The following is a description of a gene set: Human Gene Set: GATA1_04 Genes having at least one occurrence of the motif NNCWGATARNNNN in the regions spanning 4 kb centered on their transcription starting sites. This matches the GATA1 transcription factor binding site V$GATA1_04 (v7.4 TRANSFAC). studied in species Homo sapiens, and this is the list of marker genes: CLCN5, PRDX2, CHCHD7, ROS1, MAP4K5, MYOT, PCDH7, MSR1, HES1 (hes family bHLH transcription factor 1), TFR2, PDZD2, SLC26A7, IL34 (interleukin 34), RBPMS, APOBEC2, TFAP2D, NR5A2, CTCF, CEBPB (CCAAT enhancer binding protein beta), HBZ, TSPEAR, RHOBTB2, CALM2, TNXB, TACC1, NFE2, IGF1, TFEC, HOXB9, SLC8A3, MYO1C, ISL1, LRR1, SLC35A2, SYNPO, ARHGEF37, BIRC8, PRSS1, HIC1, DRD3, CPLX2, TMEM196, PPP2R3A, ARPC2, IP6K2, GUCA2A, SLITRK2, KIF3C, JUN, NEUROG3, MMP23B, CNN1, LINC01341, HS3ST4 (NCBI Gene Id 9951), ADM, SYN1, PRR18, CACNB3, PAN2, HOXC12, TCF21, UBE3A, WFIKKN2, LIN28A, HIPK1, KIRREL2, EFHC2, SAMD11, ALDH1A1, MBNL2, CCSER2, MAP4K3, KLF1, CELA3A, SCUBE3 (NCBI Gene Id 222663), MOGAT2, GBX2, ICAM4, GPX5, BNC2, TSC22D3, AMHR2, TBX5, ZBTB20, FBXL18, FAM76A, ALDH18A1 (aldehyde dehydrogenase 18 family member A1), CD34, C3AR1, HOXA10, HAMP, PON3, BMP6, IL5, HOXA13, TAFA1, PLAG1, MMP23A, PLCXD2, SPATS1, MAMDC4, ESRRB (estrogen related receptor beta), GATA1, TSHB, MSI2, MST1, PRKAA1, PDGFRA, FZD4, EDA, ECHDC2, UBE2H, SLC41A1, CAPN1, PAPPA, PHF21A, INTS5, EPO, PRELID1, P3H2, LMO2, PITX2, RNF185, EPB42, SEMA4D, C22orf31, PTGDR2, CLDN14, SLC14A1 (NCBI Gene Id 6563), CELA3B, RORA, HOXB7, BSN, RUNX1T1 (NCBI Gene Id 862), NDUFA4L2, AIF1L, DSPP, EYA4, CCL27, CYP11A1, CALHM5, GADD45G, TNFRSF19, ABCA12, SRSF1, SYNE1, ZIC1, ZNF385B, MECOM, PKIA, LUC7L3, ABCG8, CCDC80, COL17A1, AQP2 (NCBI Gene Id 359), ID3, HOXD1, CASZ1, CALD1, TWIST1, DNAJB4, PNLIPRP2, XIRP1, S1PR2, PRSS3, PNLIPRP1, FLI1, FAM117A, RAB3C (NCBI Gene Id 115827), RALGPS2, FBXO11, PTPRR, NRP2, MYBPC3, WNT6, GRID2, MITF, CDC42EP3, MAML3, HNF4G, PLEKHG6, GSE1, CSF2, EGFLAM, TRPS1, INHA, DMD, PGGT1B, ANKS1B, NR3C1, ADAMTSL1 (ADAMTS like 1), NHLH2, HTR7, CREB5, FOXP2, MAGED2, NFRKB, IFRD2, NOL4L, PNOC, LYL1 (NCBI Gene Id 4066), RAB24, ANK2, SOBP, EN1, IL3, HOXC10, AMBN (ameloblastin), NEUROD6, CREBL2, SIX1, POU4F2, SLC26A9, TNNC1, PI15, ENO2, UBE2F, NDRG2, RARB, KLF12, PRG2, SFRP5, FEV, STAG2, MYRF, ABCG5, TAB2, EGR2, FMO1, PIK3R3, TMEM65, ENOX1 (NCBI Gene Id 55068), GRM3, ATN1, ZDHHC1, LINC00656, IMPG1, GRIN2B, SLC4A1, PSD4, UBE2W, MTMR4, CNTF (NCBI Gene Id 1270), RNF123, CAST, LINC00670, CXCL13